The following is a description of a gene set: Synapses constitute highly specialized sites of asymmetric cell-cell adhesion and intercellular communication. Its formation involves the recruitment of presynaptic and postsynaptic molecules at newly formed contacts. Synapse assembly and maintenance invokes heterophilic presynaptic and postsynaptic transmembrane proteins that bind each other in the extracellular space and recruit additional proteins via their intracellular domains. Members of the cadherin and immunoglobulin (Ig) superfamilies are thought to mediate this function. Several molecules, including synaptic cell-adhesion molecule (SynCAM), N-cadherin, neural cell-adhesion molecule (NCAM), Eph receptor tyrosine kinases, and neuroligins and neurexins, have been implicated in synapse formation and maintenance (Dean & Dresbach 2006, Craig et al. 2006, Craig & Kang 2007, Sudhof 2008). Reactome Pathway: Protein-protein interactions at synapses species: Homo sapiens part of: Neuronal System, and this is the list of marker genes: HOMER2, LRRTM2, NRXN3, GRIN2A, GRIA1, DBNL, SLITRK3, SLITRK4, IL1RAPL2, PTPRF, IL1RAPL1, HOMER3, LRFN2, EPB41L1, CASK, DLGAP2, SLITRK6, LRFN3, NLGN4Y, EPB41L5, LIN7A, GRIA4, SHANK2, APBA2 (NCBI Gene Id 9029), PPFIA4, SIPA1L1, DLG1, DLGAP3, HOMER1, LRFN4, PTPRD, GRIN2C, SLITRK2, SHANK1, NLGN4X, FLOT1, NRXN2, PTPRS, DLG4, PPFIBP2, SHANK3 (SH3 and multiple ankyrin repeat domains 3), NLGN3, SYT2, SLITRK1, GRM5, LIN7C (NCBI Gene Id 55327), PDLIM5, DLGAP1, APBA1, SYT12, STXBP1, STX1A, GRIA3, LRRTM4, IL1RAP, GRIN2B, BEGAIN, NTRK3, LIN7B, RTN3, SYT9, PPFIBP1, PPFIA2, NLGN2, SYT1, PPFIA1, EPB41L3, LRRC4B, SLITRK5, SYT7, GRIN1, LRRTM3, SHARPIN, NRXN1, GRIN2D, DLG2, APBA3, SYT10, DLG3, EPB41L2, LRFN1, GRM1 (NCBI Gene Id 2911), PPFIA3, LRRTM1, FLOT2, NLGN1, DLGAP4, EPB41